Given this list of marker genes XDH, AMPD3, HPRT1, PRTFDC1 (phosphoribosyl transferase domain containing 1), NT5C, DNPH1, PNP, NT5C1A (5'-nucleotidase, cytosolic IA), NT5E, GDA, ADA, NT5C2, here is a description of the gene set: Human Gene Set: GOBP_PURINE_NUCLEOSIDE_MONOPHOSPHATE_CATABOLIC_PROCESS The chemical reactions and pathways resulting in the breakdown of purine nucleoside monophosphate, a compound consisting of a purine base linked to a ribose or deoxyribose sugar esterified with phosphate on the sugar. species: Homo sapiens